Given this list of marker genes FLNC, SCN5A, FHOD3, PLD1, KIF20A, CORIN, MYH7, NPPA, TLL1, FHL1, SCN1B, MYL3, TNNT2, MYL2, NAA10, GYS1, MYPN, STRA6, FOCAD, TNNI3, LMOD2, NUP155, SGO1, BANF1 (NCBI Gene Id 8815), RARB, here is a description of the gene set: Any structural abnormality of the left atrium. Abnormal left atrium morphology Human Gene Set: HP_ABNORMAL_LEFT_ATRIUM_MORPHOLOGY studied in species Homo sapiens